The following is a description of a gene set: Human Gene Set: KEGG_MEDICUS_VARIANT_MUTATION_CAUSED_ABERRANT_HTT_TO_RETROGRADE_AXONAL_TRANSPORT Mutation-caused aberrant Htt to retrograde axonal transport. Pathway ID: N00977. Pathway type: Variant. Pathway class: nt06461 Huntington disease. studied in species Homo sapiens Pathway Definition from KEGG: (HTT*+HAP1) -| (DCTN+DNAH+DNAI+DNALI1+DNAL) == (TUBA+TUBB), and this is the list of marker genes: DNAH6, TUBB, DCTN1, TUBA8, TUBA3D, TUBA1C, DNAH8, TUBB2B, HAP1, DNAI2, DNAH10, DCTN6, DNAL4, TUBA1A, DCTN4, TUBB8, DNAL1, ACTR1B, DCTN5, ACTR1A, TUBB2A, DNALI1, TUBA3C, TUBA3E, DNAH7, TUBA4A (tubulin alpha 4a), DNAH11, TUBB6, DCTN3, HTT, DNAH1, DNAH12, DNAH9, ACTR10, DCTN2, DNAI1 (dynein axonemal intermediate chain 1), TUBB1, DNAH3, TUBB4A, DNAH2, DNAH5, TUBB3, DNAH17, TUBB4B, TUBA1B